Given this list of marker genes Pnpo, Kmo, Fads2, Ptges, Ptgds, Gpx3, Selenok, Tbxas1, Mtr, Cat, Alox5, mt-Co1, mt-Co2, Selenop, Mthfr, Fads1, Gpx1 (glutathione peroxidase 1, NCBI Gene Id 14775), Xdh, Gpx6, Gsr, Gpx2, Gpx4, here is a description of the gene set: Selenium micronutrient network Mouse Gene Set: WP_SELENIUM_MICRONUTRIENT_NETWORK species: Mus musculus